Given this list of marker genes EML4, PTPMT1, P2RY10, DDX20, NRBF2, HBM, DENND3 (NCBI Gene Id 22898), GET4, RFLNB, MIER3, MMD, GIGYF2, ID3, EGR2, RAPGEF2, BIRC3, ZFY, GFOD1, B3GNT2, CLU, ERN1, WTAP, CREBRF, MAPK8, DTX4, MFAP1, STK17B, TMEM70, HBQ1, FYTTD1, BNIP2, GPATCH2L, KRAS, AHCTF1, U2SURP, ELF2, ELAVL3 (NCBI Gene Id 84241), PRDX6, AKIP1, SBDS, XRN1, AP5M1, SLC25A30, MIR23AHG, ATF7IP2, IST1, CXCL8, GOLT1B (NCBI Gene Id 51026), BASP1, ARL8A, SUSD6, FPR2, THUMPD1, ZNF529, SERTAD1, VCPIP1, TMEM68, TM2D2, PKN2, GNA13, NGDN, BRAF, LYPD3, CHD7, AKAP8, CACUL1, KHNYN, GOLGA4, BACH1, ZNF844, CTBS, EGLN1, PEX2, RBBP6, ZNF394, ATXN7, ZNF14, MRM3, ZZEF1, NUDT4, RGS2, ABCA1, KIF1B, PRDM4, CD83, ADGRG3, TRIM23, TRMT10C, NFKBID, HBA1, KMT2E, GPD1, UTP23, USP19, BCL2A1, PAIP2, PF4, PTGS2, STRAP, SIAH2, RAB8B, SVIL, MPC2, PAPOLA, TBPL1, GTPBP4, IRF2BPL, XKR8, MGAT4A, SPARC, AP1G1, SLC3A2, VTI1A, MGAM, TGIF1, ZNF830, SP3 (Sp3 transcription factor), CHMP1B, PIM3, ELF1, RNF11, BICRA, GMFB, MCL1 (MCL1 apoptosis regulator, BCL2 family member), ZNF586, HERPUD1, HINT1 (NCBI Gene Id 3094), RYBP, NINJ1, USP30 (NCBI Gene Id 84749), SNRK, SFXN1, SS18L2, B3GNT5, RBM33, HMGCS1, THSD1, ASCC3, L3MBTL3, NAMPT, ARIH2, SNN, ESS2, KBTBD4, COQ10B, TRAPPC4, HAPSTR1, PDE12, FPR1, MAP2K7, JMJD6, LRRC8A, IFIT5, DNAJB1, GADD45A, BCAS2, B4GALT1, ZFAND2A, MED23, IP6K2, PDRG1, RSRC2, SNORD89, R3HDM4, CHMP2B, NET1, CDC42, KAT7, UBAP1, MAPK6 (NCBI Gene Id 5597), DDIT3, MARCHF8, PLAUR, ZNF267, SLC25A36, BBX, MALSU1, RNMT, DDX50, COPS2, ZNF689, CCNG2, HSPA9, ZNF655, SLC2A14, TRIB1, SIPA1L2, RGS1, BCL7A, TIPARP, PPP1R2, BTG1, MTMR3, VNN3P, IFITM2, ATXN1L, FBXL12, KLHL28, ZFX, PNPLA8, LCOR, SGTB (small glutamine rich tetratricopeptide repeat co-chaperone beta), MEOX1, PIGB, SAMSN1, CFL2, AZI2, ARHGEF7, EAPP, PPM1A, ZRANB1, FNIP1, ATP1B1, PHC3, LAMTOR3, MXD1, DUSP10, TGIF2, NUB1, RCL1, DUSP8, SDE2, LRATD2, UBE2B, PROK2, ZEB1, GAB2 (GRB2 associated binding protein 2), SMPD4, SUB1, IL1R2, TIMM23, PPP4R3A, RANBP6, ITPRID2, SLC2A3, PLEKHF2, RSL24D1, ABHD17B, ARHGAP5, C5AR1, ING3, B3GNT7, SREK1IP1, TIMM10B, PPP4R3B, MIER1, KCMF1, FOSL2, TSPYL1, PTPRE, PPP1R15B, TPRG1L, TRAF6, DDX47, KLF3, GCOM1, ATP5IF1, AMFR, S100P, RAB18, MFSD14A, G3BP2, SIK3, ENC1, ZNF134 (zinc finger protein 134), THBS1, DYNLT1, CXCR5, BNIP1, ZBTB1, CUL1, IVNS1ABP, EIF1B, FBXO28, TCP11L2, GMEB2, PLPPR2, PTGER4, TUBA1A, SP100, NUFIP2, HSPA14, GTF2IRD2, ADAM22, OSBPL2, NSMCE3, ZNF18, SLC12A6, RUBCNL, TM2D3, KLHL2, KLHL21, MTMR10, STX11, RRAGD, DCP1A, ACSL1, SNHG8, SLC17A7, PDE4B, PER1, CLP1, CCDC174, TMEM183BP, MOB4, NDST1, RPS24, WBP11, RIT1, NUAK2, ZNF548, PTPRK, BEX4, ARK2N, WDR45B, RAD23B, ANKHD1, PET117, ARID5A, SNRNP27, H2AC6, ETV3, ERO1A, MED26, IFNGR1 (interferon gamma receptor 1), YPEL5, ARPP19, CWC15, ZBTB18, MTHFD2L, ADO, EGR3, DNAJC3, CLEC2B, NIPA2, ABT1, RAB11FIP4, NECAP1, PRP4K, DDX21, MMP9, PPP2R1B, PAX5, BEX2, ZNF639, MME, SLC25A37, GTF2B, MTERF4, IKZF5, SYS1, GABARAPL1, SOCS1, RPF1, WDR20, KDM5B, KLHDC2, MNT, SF3A1, OTUD1, POLR1C, ZFP36L1, PPP1R3B, CXCR1, HNRNPA0 (NCBI Gene Id 10949), PIM2, IRGQ, BEX5, HMGXB4, EHD4, CDK16, NCOA1, ITPRIP, KDM6B, NDUFAF5, CDKN1B, ZNF24, UBXN6, DUSP12, POLR3F, ZFAND6, REL, TFRC, JMY, NOL11, RPS6KB1, RAB43, SPOPL, SRGN, RC3H2, TRIM58, LMTK2, SPECC1L, MED21, RBM8A, FBXO33, SLU7, DEFA3, SNHG15, AEN, C6orf226, SERPINB2, BLTP3B, RIPK2, RAB11FIP1, LITAF, FNDC3B, BUD31, CPEB4 (cytoplasmic polyadenylation element binding protein 4), LIMK2, IFRD1, FAM169A, MED30, TNFAIP6, MRPL47, KANSL2, VPS18, DYRK2, HIF1A, ZBTB5, ETF1, TNFRSF10C, GABARAPL3, PHLDA1, ICAM1, NR1D2, ADIPOR1, PDE4D, AKIRIN2, RMND5A, SLC7A5, MIR22HG, PAIP1, NDEL1, GGNBP2, SIK1, TSFM, LPAR2, ZNF622, IDI1, RASGEF1B, GNE, TPSG1, SEC31A, TERF2IP, PCNX1, TUBA1C, ZNF571 (NCBI Gene Id 55594), BAG5, PRC1, RPAIN, VPS37B, PLCL1, PRDM2, MAFK, WDR48 (WD repeat domain 48), BCL2L11, SNCA, TENT5C, ZNF395, NGRN, NUP98, VAV2, RBM15, BZW1, PNO1, POLR2M, EIF1AX, DIDO1, UQCRC2, YTHDC1, ANXA3, HSPA13, NUP153, TMEM167B, MED6, HBG1, CNOT8, CYSTM1, CMTM6, MARCHF7, GCC1, PHACTR1, ZNF10, MXD4, RPRD1B, RAP2C, RBM7, HNRNPH3, DEFA1B, G0S2, SAMD8, PRRC2C, MAPKAPK2, HSF2, MTPAP, CCL28, TPM3, FHIP2A, THBD, CHPT1, EIF1AD, MAD2L1BP, MYLIP, TSPYL4, MAP3K8, YBX3, CASZ1, PTP4A1 (NCBI Gene Id 7803), TLE3, CCDC59, IRS2, COIL, SLC25A28, ISCA1, ARID4A, SOCS3, METAP2, RBMXL1, ITCH, PCIF1, KBTBD8, GPR65, GSN, SLC19A2, RBM18, CNEP1R1, EID3, FBXO7, HAUS3, NSF, TMEM38B, FAM53C, ZBTB33, CXCL1, KBTBD2, DDX27, DUSP5, HOXA5, TOPORS, GK, ZMYM2, KLHL15, MBOAT7, MEX3C, ZNF326, DHRS3, VCPKMT, NFIL3, USPL1, MXI1, ATP2A3, UBALD2, IDS, AQP9 (aquaporin 9), UBE2G1, KRR1, PHF1, RNF103, MCPH1, KPNA4 (karyopherin subunit alpha 4), BTG3, LONRF1, RNF6, TADA2B, ARMH3, RLF, SUMO3, EAF1, CCNT2, NEDD9, SOD2, HAVCR2, ZBTB10, PLAGL2, DCAF16, MED28, SERPINB1, CCNK, TFAM, GPR183, GYPC, OSER1, C18orf21, USP42, CHD2, CCDC28A (coiled-coil domain containing 28A), MAP1LC3B, RAB1A, SELENOK, CDC40, PHF11, ZFAND4, TMEM243, PDCL, NUP58, ANKRD37, RNF4, ZNF552, HP1BP3, ZC3HAV1, BCL10, HIC2, CHSY1, SYTL3, BTG2, HNRNPL, PPP2R2A, SLCO3A1, C1orf52, LRRC8B, STK35, ODC1, CXCL2, CAMK2D, VCF1, NUDT15, USF3, EIF1, MEPCE (NCBI Gene Id 56257), MEF2D (NCBI Gene Id 4209, myocyte enhancer factor 2D), ZBTB43, COG5, GZF1, EXOC8, DDX6, IFITM1, UBE2J1, H2AZ2, AMD1, USP12, CBX4, MKRN1, PIK3R1, KAT8, DPM1, CYRIA, GLUL, PSMD12, EIF5, TMF1, SCAF11, FOXO3, SUN1, CCDC50, DUSP11, SERINC5, AMPD2, CSRNP1, TAMALIN, RABIF, TREM1, MAIP1, RORA, FAM8A1, ATP11B, CAVIN2, UGCG, EPB41L4A-AS1, HCAR3, CDK17, DERL1, FBXO21, BCLAF1 (BCL2 associated transcription factor 1), PRKAR1A, GSPT1, SNIP1, GPR18, USP15, CD55, QKI, DOCK4, AZIN1, GRPEL1, C1D, COX4I1, NRIP1, TIMM17A, RIOK3, ZNF350, ANKRD9, ZNF331, HBB, ATAD2, BAG3, MTMR6, SERTAD2, NRAS, RRM2B, JUND, KDM7A, PRELID3B (PRELI domain containing 3B), MAX, TRIM13, KIAA1143, BNIP3L, LY9 (NCBI Gene Id 95630), C3orf38, MAPK1IP1L, DUSP2, BAZ2A, CLC, SH3GLB1, RBM48, RAB20, ABHD5, AREG, FEM1B, HBEGF, TMCC3, PPIF, HBA2, ORAI2, ALG13, PELI1, RBSN, SLC25A33, WHAMM, ADORA2A, DEFA1, RELT, ADAM28, AP3M2, RLIM, LARP7, DNTTIP2, LRG1, GNL1 (G protein nucleolar 1 (putative)), ELL2, ITPKB, ZNFX1, TOX4, MAP2K3, CMTM2 (NCBI Gene Id 146225), PNPLA2, DIS3, C11orf58, RALGPS2 (NCBI Gene Id 55103), PMAIP1, GAS5 (NCBI Gene Id 60674), NR4A2, CDADC1, FASTKD5, RNF139, SMNDC1, RASSF5, PPARD (peroxisome proliferator activated receptor delta), INSIG1, NR4A3, CDKN2D, KDM2A, ZNF644, CXCR4, HECA, CYTIP, NFYC, SKP1, ZNF766 (NCBI Gene Id 90321), YTHDF2, SNRPA1, ZXDB, PTPN2, TWF1, OSM, CCDC71L, MAP3K2, PKD1, HNRNPH2, RAMAC, RAB2A, IL1B, TIFA, ZCCHC2, MED13L, ACTR3, GOSR1, NAA50, PPBP, SEC14L1, NFE2L2, DBF4, BCL6, SPTY2D1, ZNF92, ATG2A, MMADHC, PELO, CNOT6L, BCL3 (NCBI Gene Id 602), YTHDF3, SAR1A, PPTC7, MATR3, ELL, ZNF281, DYNLL2, USP36, YOD1, CPEB2, GPR160, RAB21, LEPROTL1 (leptin receptor overlapping transcript like 1), CREM, ZNHIT3, MOAP1, DNAJB9, SYNCRIP, MTMR14, ZBTB21, PPM1B, ILF3, PDCD4, TGS1, KLF7, HIP1R, ARPC5L (NCBI Gene Id 81873), ICOS, VAPA, FEM1C, HBG2, PDZD8, PCGF5, JARID2, RNF138, H3C10, JMJD1C, SIAH1, SEMA4D, SMURF1, GUK1, TMEM183A, PFKFB3, TFG, TP53BP2, TNIP1, ABHD13, DCTN6, ASNSD1, JADE1, MRPS22, SMAD4, HBP1, ETNK1, ANKRD13C, here is a description of the gene set: from publication Nakaya HI, Wrammert J, Lee EK, Racioppi L, Marie-Kunze S, Haining WN, Means AR, Kasturi SP, Khan N, Li GM, McCausland M, Kanchan V, Kokko KE, Li S, Elbein R, Mehta AK, Aderem A, Subbarao K, Ahmed R, Pulendran B (PMID 21743478) Here we have used a systems biology approach to study innate and adaptive responses to vaccination against influenza in humans during three consecutive influenza seasons. We studied healthy adults vaccinated with trivalent inactivated influenza vaccine (TIV) or live attenuated influenza vaccine (LAIV). TIV induced higher antibody titers and more plasmablasts than LAIV did. In subjects vaccinated with TIV, early molecular signatures correlated with and could be used to accurately predict later antibody titers in two independent trials. Notably, expression of the kinase CaMKIV at day 3 was inversely correlated with later antibody titers. Vaccination of CaMKIV-deficient mice with TIV induced enhanced antigen-specific antibody titers, which demonstrated an unappreciated role for CaMKIV in the regulation of antibody responses. Thus, systems approaches can be used to predict immunogenicity and provide new mechanistic insights about vaccines. studied in species Homo sapiens Genes down-regulated in peripheral blood mononuclear cell 7d vs 0d in adults (18-50) after exposure to FluMist, time point 7D. Comment: Supplementary Table 1a: All the differentially expressed genes identified in PBMCs of TIV vaccinees. Human Gene Set: NAKAYA_PBMC_FLUMIST_AGE_18_50YO_7DY_DN